Given this list of marker genes EFNA5, TGFA, EREG, IGF2, GREM1, HBEGF, EGF, ALKAL2, BTC, VEGFA, ANGPT4, EPGN, IGF1, NRG3, NGF, ALKAL1, DGKQ, NRG1, AREG, here is a description of the gene set: studied in species Homo sapiens Binds to and increases the activity of a transmembrane receptor protein tyrosine kinase. Human Gene Set: GOMF_TRANSMEMBRANE_RECEPTOR_PROTEIN_TYROSINE_KINASE_ACTIVATOR_ACTIVITY